Given this list of marker genes UCHL1, SYBU, MAP1S, WASF1, SPAST, KIFBP, MGARP, FEZ1, TRAK1, AGTPBP1, RHOT2, LRPPRC, TRAK2, MAPT, AGBL4, OPA1, UXT, HIF1A, UBB, ACTR10, MAP1B, KIF5B, RHOT1, NEFL, HDAC6, HSBP1, KIF1B, ARMCX3, here is a description of the gene set: Human Gene Set: GOBP_ESTABLISHMENT_OF_MITOCHONDRION_LOCALIZATION_MICROTUBULE_MEDIATED The directed movement of the mitochondrion to a specific location, by a process involving microtubules. studied in species Homo sapiens